The following is a description of a gene set: Genes containing one or more binding sites for (Ikzf3) in their promoter regions (TSS -1000,+100 bp) as identified by GTRD version 20.06 ChIP-seq harmonization. from publication Yevshin I, Sharipov R, Kolmykov S, Kondrakhin Y, Kolpakov F (PMID 30445619) Mouse Gene Set: IKZF3_TARGET_GENES studied in species Mus musculus, and this is the list of marker genes: Rps21, Fam221a, Mcoln3, Polg, Rps6ka1 (NCBI Gene Id 230803), Bivm, Neil1, Gm7285, Cert1, Mir3960, Mir1903, Chmp5, Bcl3 (B cell leukemia/lymphoma 3), Map4k2, Gpbp1, Socs2, Ap5b1, Elk3, Rimoc1, Ptges3, Serpinf1, Fus, Commd3, Casp7, A430093F15Rik, Tmbim6, Klf13, Cenpl, Cnot6, Lgals7, 1600023N17Rik (NCBI Gene Id 69788), Cblc, Pygo2, Spty2d1, Mir8120, 6030443J06Rik, Mapkapk5, Ttc28, Tcf19, Ptcd1, Itpripl2 (NCBI Gene Id 330636), Cdk20, Gcat, Nrm, Nup93, Tmbim4, Armc7 (armadillo repeat containing 7), Anapc16, Rnf216, Echdc3, Appbp2os, Klf9, Vamp4, Mib1, Man1a (mannosidase 1, alpha), Mir7653, Agfg1, Stk3, Hsd17b12, C2cd2, Gon7, 5730455P16Rik, Ints5, Txndc12, 2310030G06Rik, Fam98a, Tbkbp1, Itsn1, Pan3, Rpl13a, Arpp21, Lancl2, Mrps34, Mmachc, Grn, Heatr3, Vti1a, Cntrl, Wdr77, Tmem170b, Igkv13-82, Wrap53, Extl2, Pde6d, Cep41, Faap20, Gm15411, Megf8, 1700041G16Rik, Tlr4, Huwe1, A930006L05Rik, Cdh24, Bhlhe40, Btaf1, Stil, Fis1, Tet3, Erc1, Rrad, Timeless, Cdipt, Ppp1ca, Hsd17b4, B4galt5, Nfkbil1, Ubtf, Atp5mc3, Agpat4, Pcyt1a, Shprh, Gm23205, Ppp2cb, Ggnbp2, Dnajc1, Cilk1, Lrrc49, Mgarp, Scaf4, Spo11, Mef2d, Igsf8, Ndufs2, Akirin1, Dusp6, Mcm3, Adipor1, Mir1938, Alkbh5, Rag1, Rdm1, Rinl, Mir6361, Ston2, Klhl9, Ppp1r12b, Msh6, Mcl1, Ucp2, Ulk2, Gbp7, Zmynd8, Creb3l2, Lyrm2, Tmem87b, Apba1, Rnpep, Adam10, Vpreb1a, Tmx3, Rab35, Cimip2b, Mmut, Apc, Rsrc2, Nrdc, Rac1, Fnip2, 3110009E18Rik, Stat6, Frg2f1 (NCBI Gene Id 433752), Arfip1, a, Helz, Abhd18, Mmp14, Mex3c, Creb1, Spef2, A530072M11Rik, Mir7071, Eogt, Polr3b, Haus2, Tgif1, Neu3 (NCBI Gene Id 50877), Melk, Cep72, Chd9, Trappc9, Stx16, B3galnt2, Nudt16, Ankib1, Rab12, Pfkfb3, Gnb2, Cap2, Arih2, Adnp, Hexim1, Psma1, 9330136K24Rik, Cd3e, Calhm2, Arap1, Zbtb3, Polr3gl, Strip2, Pafah1b3, Gpt2, Dhrs7 (dehydrogenase/reductase 7), Bod1l, Gm17399, Atg14, Rps6ka2, Ankrd42, Arf2, Phip, Mcf2l, Ccdc88a, Kri1, Midn, Pold4, Gngt2, Carf, Mapk14, Cstf3, Calu, Dclre1a, Tradd, Lef1 (NCBI Gene Id 99641), A930002I21Rik, E230015B07Rik, Plxnd1, Arih1, Bag1, Usp46, Fam210a, Gm7008, 2810429I04Rik, Hipk2, Tmem222, Tti1, Kat6a, Irf2bp2, Prr29 (proline rich 29), Ndufb5, Rasgrp4, Cul7 (cullin 7), Tmem132a, Lnpep, Inpp1, Ankrd24, Nfyb, Slc25a30, Nbn, Rgl1, Gm10644 (predicted gene 10644, NCBI Gene Id 100126034), Nr1h3, Mettl21a, Etfb, Ptpn6, Suz12, Picalm, Rrp1, Ncoa2, Gm11613, Ten1, St7l, C87436, Tac4, Gm24000, Oard1, Chst10, Gm15417, Cst3, Phlda1, Dusp9, Cox14, Dbndd2, Traf1, Lpp, Tmem198b, Eva1b, Trpm8, Rab6a, Zfp91, Acp2, Ecsit, Rtn4, Gm17509, Hmbox1, Fam13a, F730043M19Rik, Rab4b, Arpc3, N4bp2, Gtf3c3, Zfp882 (zinc finger protein 882), H2-DMb2, Hnrnpll, Socs1 (suppressor of cytokine signaling 1), Vapa, Gne, Rgs3, Nrn1, Dzip3, Mir7655, Igsf10, Nfkb1, Gls2, Rcbtb2, Cuedc1, Pum3 (NCBI Gene Id 68885), Usp28, Gin1, Ttc39b, Dapp1, 1700001G11Rik, Ints9, Gm5540, Tbl3, Vps35l, Rhot1 (NCBI Gene Id 80692), Txn2, Thap7, 1810021B22Rik, Camta1, Commd4, Pih1d2, Msto1, Atp5pf, Grcc10, Fbxl4, Tyms, Usp32, Gabarapl2, Ubr1, Dmtf1, Srebf2, Mesd, Hsp90aa1, C78197, Gsto1, Snx21, Kat2b, Galnt2, Iqgap2, Mzf1, 9330159M07Rik, Htra2, Plpp3, Cipc, Zfyve1, Gm13982, Arid4a, Tnks (NCBI Gene Id 97475), Ippk, Hvcn1, Mlf2, C2cd3, Trp53i11, Dennd4c, Spmap2l, Nsd3, Efl1, 4631405J19Rik, Eya2, Acot8, 4833445I07Rik, Ampd2, Ctdsp2, Syde1, Eif2s1, Zfp326, Mttp, Inpp5d, Tfcp2, Gm57488, Plekhf1, Dock1, Uba2, Ppp2ca, Arid3b (AT-rich interaction domain 3B), Trbv31, Tsn, Tmem63a, Gsdmd, Gramd1a, St13, Foxp4, Cd47, Cecr2, Cenpu, Dgka, Mir3569, Ptprv, Arhgap31, Nrp1, Epb41l4b, Slc1a5, Nfkbia, Zfp281, 2010001A14Rik, Slc30a7, Uba7, Csrp2, Sestd1, Lonp2, Ttc39d, Pitpnm2, Prdx1, Mphosph9, Phykpl, 9230116N13Rik, Il17re, Malt1, Gphn, BC028471, Nfia, Ebf3, Mvb12a, Arpin, Mcrs1, Mrps25, Mtrfr, Ndfip2, Kctd18, Dvl3, Trerf1, Ccdc107, Syne3, Vrk3, Prkag1, Catspere2, Nhp2, Gm26802, Farsb, Gm5547, Sap30l, Csrp1, Rab1a, Dmap1, Adgrg1, Trim3, Pnn, Anapc7, Clpx, Adam17, Hbegf (NCBI Gene Id 225370), Mef2c, Mrpl21, Slc16a1, Rbbp8, Sh3rf1, Cntn2 (contactin 2), Tst, Gm12500, Tead4, Nhlrc2, Nhsl1, Ints3, Zscan12, Stn1, Pdzd2, Slc43a2, Zmynd12, Etv6, Spata6l (spermatogenesis associated 6 like), Ccar2, Mzt2, Pank2, Edaradd, Sfr1, Abtb1, Duoxa2, Map4, 1700003D09Rik, Gpr137, Hpcal1, Ramp1, Mir24-2, Mthfd1l, Mrps33, Pigw, Efcab14, Eif1ax, Dbi, Dusp5, Zfp609, Hnrnpul2, Fam110a, Pdk2, Wdr12, Igll1, A630014C17Rik, Rps19, Ncald, Ndufaf3 (NADH:ubiquinone oxidoreductase complex assembly factor 3), Trip4, Erc2, Kansl1, Setd7 (NCBI Gene Id 73251), Eps15 (epidermal growth factor receptor pathway substrate 15), Nabp1, Khdrbs1, Zbtb5, Antxr2, Myo19, Galnt10, Orc1, 0610038B21Rik, Prc1, N4bp2os, Pkn3, Cyfip1, Gpr19, Glrx2, Polr3d, Rbm25, Eml6, Acox1, Rab13, Cbfa2t3, Myo9b, Fam72a, E130102H24Rik, Mmgt1, 1700003G18Rik, Lpin2, Ppp1cb, Il16, Plekhg1, Cyb5a, Ssr3, Tecpr1, Zbtb44, Pik3cd, Crkl, Itm2c, Rfc1 (replication factor C (activator 1) 1), Gm16998, Dnajc13, Appbp2, Rexo4, Kyat3, Ubl5, Pals1, Klhl20, Fhod1, Mrpl32, Mir7666, 5031434O11Rik, Tfb1m, Fam3c, Ddx20, Ptbp3, Xrcc6, Gm33994, Slc39a8, 6720483E21Rik, Rab21, Myo18a, Ccdc163, Dynlt5, Notch2, D030040B21Rik, Slc15a3, Epo, Actr8, Hnrnpk, Dars2, Slc25a11, Mars2, Marveld1, Mir2861, 4930509H03Rik, Gm17484, Phactr4, Flrt1 (NCBI Gene Id 396184), Kmt2b, Gm11592, Cds2, Ppm1a, Clcn2, Ska3, F2r, Zfp318, Fchsd2, Gtf2f2, Ralgds, Tlr5, Osbpl1a, Sla, Fndc3a, Napg, Cd160, Csgalnact1, Cplx2, Kntc1, Gm6712, Btf3l4, Ppme1, Pxn, Gm26021, Zfp467 (zinc finger protein 467), Gtpbp2 (GTP binding protein 2), Ube3a, Sumo1, Heatr5b, Exoc3l, Akr1e1, Birc6, Idh1, Wdr36, Atp5mk, Luzp1, Cdk5, Sucla2, Serinc5, Dpy19l4, Vgll4, Foxp1, Ccdc88c, Caap1, Tmem176a, Lig1, Mir6936, Tha1, Tasor2, Ubash3a, Polg2, Vcl, Sbf2, Prkar1a, Sirt6, Tfpt, Zfp597, Jarid2, 2310010J17Rik, Rprd1b, Gm19569, 5830437K03Rik, Wscd1, Gm5558, Aamdc, Cnih4, Alkbh3, Abcg2, Asxl2, Sys1, Lat, Fbxo28, Mfsd10, Taf6l, Pisd, Gm10699, Lyrm1, Prkra, Mical1, Ganc, Calm1, Lbh, Dennd6b, Rcsd1, Tnk2, Ptms, Tbc1d32 (NCBI Gene Id 544696), Pik3r4, Cdc7, Cmc1, Pja2, Stmn1, Nfkb2, Zfp260, Tmc6, Flot2, Tob2 (NCBI Gene Id 73089), Prpf38a, Rps6ka3 (NCBI Gene Id 331563), Gpatch11, Gm15743, Cpd, Fbxo42, Ddx55, Nmnat1, Gm22890, Fstl4, Mlec, Pomgnt1, Tor1aip2, Stat1, Eif5, Capn3, Tnfrsf1a, Hdac7, Utp3, 4933406C10Rik, Rbfox2, Snap23, Zbtb7b, Mir27a, Pak1ip1, Bmyc, Rmrp, Cpsf4l, Gm30238 (NCBI Gene Id 102632066), Pik3r1, Tfg, Dusp11, Maz, Prmt5, Bloc1s1, Cln8, Nab2, Spred1, Dis3l, 5730471H19Rik, Hemk1, Gm26611, Gm42759, Lrrc1, 4933439C10Rik, Gm12059, 1700025G04Rik, Zbtb14, Endov, Hnrnpl, Mettl9, Fhip1b, Fbxl12, Cdk9, Dclre1c, Fam78a, Cep19, Igsf9, Gpaa1, Ttbk2, Nutf2, Agk, C1qtnf12, Parvg, Ctsd, Senp2, Adcy7, Sde2, Mrpl48, Noct, Cep70, Dctn1, Rbpj, Mcu, Atosa, Dpagt1, Fam3a, Gm13620, Ngdn, Tmtc3, Acaa2, Mis18bp1, Tbc1d10c, Ppcs, F13a1 (coagulation factor XIII, A1 subunit), Polk, Pex19, Rasgrp3, Smarcd2, Camsap2, Nop16, 2310044K18Rik, Khsrp, Slc9a8, Atg16l1, Rad54l, Zfp788, Tmco4, Cfap45 (cilia and flagella associated protein 45), Slc35a1, Adi1, Tmcc1, Psmd2, Ddx59, Akr1b1, Fut8, Ammecr1l, Ube2e1, Gm36981 (NCBI Gene Id 105244476), Bace1, Xiap, Jkamp, Zap70, Vsir, Taok2, Gpr180, Styk1, Esyt2, Matn2, Ctnnb1, 2810408I11Rik, Rreb1, Fxr2, Smap1, Utp25, Nsfl1c, Nfat5, Gm13421, Rhoh, Oas1c, Rab14, Wbp1l, Ift122, Asph, Fkbp1a, Mgat5, Nf1, Spats1, Tmem204, Tcf12, Raly, Sema3f, Tgif2, Gm26839, Slc44a1, Cdr1, AI480526, Tmx1, Zdhhc20, Saxo2 (stabilizer of axonemal microtubules 2), Mcur1, Rab10, Rnf185, Becn1 (beclin 1, autophagy related), Rb1, Arhgef12, Galk2, Vps26c, B230217C12Rik, Sec22a (NCBI Gene Id 69021), Oas1b, Nadk, Acp5, Mtif2, Mei4, Syk, Ogg1, Phospho1, 1110002L01Rik, Otud1, Fbxo21, Eif4a3, Gm5493, Gtpbp6, Bad, Zfp948, Tcf4, Palb2, Arhgap21 (NCBI Gene Id 98793), Rapgef3, Myo6, Tinf2 (Terf1 (TRF1)-interacting nuclear factor 2), Pik3ap1, Alms1, Pik3ca, 1700055D18Rik, Cfap276, Aaas, Kcne3, Fgd2, Atxn7l1, Scd2, Fubp3, Dctn5, Gas7, Zfp64, Optc, Bbs4, Prkci, Gm15564, Slc25a14, Hk1os, Efcab2, Mcoln1, Foxj3, Jakmip1, Blmh, Tmem18, Ttc4, Itgb2, Serhl, Ttll11, Dnai3, Htt, St3gal3, Amotl1, Rhebl1, Duox2, Ntpcr, 6430573P05Rik, Tnfaip8l1, Srf, Xrra1, Rai1, Gm16578, Copa, Nkapd1, Hivep2, Fads2, Gosr2, Cers6, Hat1, Ankrd12, Ikbkg, Trim25, Cnn3, Mepce, Tsku, Fhl4, Hmg20b, Smarce1, Mitd1, Ptp4a3 (protein tyrosine phosphatase 4a3), Plscr1, Mfng, Atxn2l, Mospd1, Elp6, Pkn1, Hdac5, Rbm43, Cep162, Map3k1, C130021I20Rik, 2610005L07Rik, Fh1, Nr1d1, Hjurp, Zdhhc6, Gas2l3, Nabp2, Gigyf2, Gm9958, Foxc1, Hinfp, Ccdc120, Hs2st1, Cep290, Tmem109, Chst3, Cnksr3, Cacnb2, Rassf5, Mir3091, Med1, Alcam, Eme2, Yap1, Slco3a1 (solute carrier organic anion transporter family, member 3a1), Rpl31, Clock, Pidd1, Gm37120, Tbc1d8b, Naa30, Tmem65, 2810402E24Rik, Shld1, Sp1 (NCBI Gene Id 68485), Wdcp, Echdc2, Dtwd1, BC043934, Spn, Lypla2, 1810008B01Rik, Gm12301, Lasp1, Lhfpl6, Matcap2, Gsk3b, 1110006O24Rik, Atn1, Smarcal1, Ddx50, Slc43a1, 1700120B22Rik, Dgkg, Cnot3, Ctnna1, 6820408C15Rik, Ric8b, Brpf1, Arl6ip5, Gabpb1, Polr2i, Rcor3, Bdh1, Bcl2l1, Zfp960, Dnlz, Kctd11, Gm266, Spin4, Slc25a38, Cchcr1, Jmy, Plxdc2, Ghr, Mir320, Exoc5, Eif4a2, Msrb2, Gstm1 (NCBI Gene Id 14862), Gm14455, Gm2093, Snx33, Acad9, Psrc1, 1700086O06Rik, Pdcd6, Ly6m, Laptm4b, Mtg2, Id3, Odr4, Mmgt2, Gm13920, Ubxn2b, Fry, 1810009A15Rik (RIKEN cDNA 1810009A15 gene), Ptpn3, Srfbp1 (serum response factor binding protein 1), Calm3, Pes1, Sh2b3, 4930589L23Rik, Ajuba (NCBI Gene Id 16475), Itgb1, Wdfy4, 1700125G22Rik, Casp2, Homer3, Bsn, Pjvk, Ophn1, Fam133b, Plpp5, Rab34, Sirt7, Degs1, 2310068J16Rik, Stoml1, Zfp473, L3hypdh, Chd8, Tbc1d23 (TBC1 domain family, member 23), Fastkd3, Klf11, Spata6, Kmt2a, Kpnb1, Pde10a, Chid1, Exoc2, 1810037I17Rik, Vangl2 (VANGL planar cell polarity 2), Lyl1, Rictor, Ubl3, Slc39a1, Gm11690, Avpi1, Nvl, Acss2, Aff1, Fn3k (NCBI Gene Id 80558), Dek, Naf1, Znhit1 (NCBI Gene Id 70103), Rnf167, T2, Hsd17b11, Eif6, Ube2e2, Ago3, Rnf20, Kansl3, Gm16894, Polr1d, Pcna, Foxo4, Dync2h1, Kctd14, Ccnd3, Mtfr1l, Trem1, Clip1, Rab5a, Gtdc1, Polm, Tsc22d1, Cacna2d2, Mtch1, Mamstr, Ift27, Rab33b, Cyria, Thap12, Gusb, Smc5, Kmt2d, Ifrd1, Slc35b2, Shb, Arhgef10, Stam2, Cep57, 9930012K11Rik, Dleu2, Selplg (NCBI Gene Id 20345), Thtpa, Rdh5, Inppl1, Pla2g6, Psmd5, Gm15927, Pramel12, Syngr1, Dnajb12, BC034090, Pakap, Phf23, Ranbp9, Notch1, Nup54, Dpysl2, Srsf7, Lmx1b, Leng9, Kifap3, Mir191, Gnai2, Snx27, Rnps1, Ost4, Rbm34, Hfe, Aplf, Pdcl3, Eif2d, Gmds, Gpatch8, Ric8a, Gm4221, Wdr3, Jcad, Ciao2b, Pip4p2, Gm17249, Zc3h12c, Cap1, Pomk, Abi3, Itgav, Fam76b, Nynrin, Esyt1, Kirrel1, Rac2, Zfp420, Pou2f1, Ssc4d, Ubr7 (ubiquitin protein ligase E3 component n-recognin 7 (putative)), A730081D07Rik, C230035I16Rik, Btbd2, Rasgrp2, Dynlrb1, Pigc, Slc45a4, Erbin, Prps2, Zfp395, Tmem87a (NCBI Gene Id 211499), Pura, Kpna4, D330041H03Rik, Lrp6, Mllt3, A730035I17Rik, Zscan22, Stag1, Chaf1a, Phf21a, Dicer1, AV099323, Brca2, Fam13b, Bmp2k, Acvr1, Haus8, Ap2a1, Zfat, Zfp286, Frmd6, Zswim3, Hook2, Cttnbp2nl, Nfam1, Elapor1, Fbxo10, Cep250, Uaca, Apbb2, Zfp36l1, Tmem229b, Nus1, Jun, Rbm45, Efemp2, Zmiz1, D930048N14Rik, Cyp2j6, Rdx, Col25a1, Ncdn, Coro1b, Prkca, Trib1, Gm11454, Ctc1, Cdan1, Gdi1, Ppp1r8 (NCBI Gene Id 230788), Abi2, Gtf2f1, Zfp267, Asb6, Filip1, Vcf1, Pigx, Iftap, Gm15327, Stam, Deptor, Fam76a (family with sequence similarity 76, member A), Gm5447, Slc4a2, Atp2c1, Mgat1, Itpk1, Rnf44, Xpnpep3 (NCBI Gene Id 321003), Eeig2, Gpx1, Il7r, Dna2, Pus10, Tvp23a, Nbdy, Dcun1d5, Capg, Scd1, Trabd2b, Slc66a3, Tlnrd1, Trip12, Emsy, Wbp4, Bmf (BCL2 modifying factor), Tmtc4, Fbxo11, Slc49a4, Tbrg4, Zbtb38, Ripk2, Gm23119, Pgls, Gm12107, Zcwpw1, Mrpl52, Med13, 4930578M01Rik, Scarna17, Stx12, Cdiptos, Cln6, Mknk2, Drosha, Cers5, Cltc, Gfra2 (NCBI Gene Id 14586), Psma2 (proteasome subunit alpha 2), Rps26, 5930430L01Rik, Trpm1, BC002059, Gm9530, Capza1 (capping actin protein of muscle Z-line subunit alpha 1), Pter, Junb, Ctdnep1, Mtmr6, Smad3, Setd1a, Tspan5, Sphk1, Stap2, Fcgr1, Dnhd1, Gtf2i, Ramacl, 8430429K09Rik, G3bp1, Top3b, Xpo5, Plekhf2, Sla2, Smim13, Cux1, Rpl36, Zfp622, Wdr11, Sypl1, Sdf2l1 (stromal cell-derived factor 2-like 1), Gng2, Ankhd1, Tanc1, Ctif, Sh2d3c, Mis12, Manba, Cfap96, Zfp944, Nmi, Taf5l, Zfp668, Cd93, Arl16, Tpr, Selenof, Spr, Npdc1, Nubp1, Gpr108, Mir7688, Mir8099-1, Frmd4a, Plekho2, Rnf31, Kazald1, Cnnm4, Rbm4b, Ttc17, Sardh, 6430548M08Rik, Mfap1a, Nwd1, Lnx2 (ligand of numb-protein X 2), Atad2, Adcy3, Zcchc7, Ppp1cc, Echdc1, Zfp408, 6030458C11Rik, Plekha6, Chrac1, AV039307, Nr2c2 (nuclear receptor subfamily 2, group C, member 2), Golph3l, Pcbp2, H1f2, Cacnb3, Vrk1, Gm25541, Osgepl1, Kat6b, 2310057M21Rik, 4930426L09Rik, Arf1, 1700036A12Rik, Mtnap1 (NCBI Gene Id 28086), Rptor, Hmgb2, Med14, Slx1b, Rhog, Lrig2, Csnk1g1, Cep170, Slc25a1, Plekha7, Arhgap1, Baz1a, Rpl29, Bbs7, Snw1, Pdcd11, Dcun1d3, Fbxl19, Hsd17b10 (hydroxysteroid (17-beta) dehydrogenase 10), Cand1, Ict1os, Podnl1, Efhc1, Pa2g4, Tial1, Plekhg3, Rab4a, Kcnb1, Lcorl, Car2, Smim30, Cimap1b, Ist1, Wiz, Tars2 (threonyl-tRNA synthetase 2, mitochondrial (putative)), Fbh1, Smg9, Ibtk, Zfp185, Zfp13, Srl, Klc3, Akna, Lzic, Usp40, Elk4, Pi4k2b, Tnks1bp1, Zfp945, Zfp111, Litaf, Nr6a1, Zfp687, Cryzl1, Ppp1r15a, Map3k12, Lrrc57 (leucine rich repeat containing 57), Vdac1, 4930558K02Rik, Cpsf4, Abhd1, Tram1, Mrpl24, Nup155, Arhgap11a, Clta, Homer1, Acaa1a, Ankrd16, Eloc, Mllt6, Fem1c, 1700028E10Rik, Lsp1, Arc, Orc5, Gm14634, Spred2, Plod3, E2f3, Cotl1, Tbrg1, Trio, Lxn, Rpl37, Mbtps1, Naa60, Rsu1, Ubap1, Pianp, Gm29707, Stambp, Myb, Gm27003, Bcl11a, Elp3, Serpinb9, 6820431F20Rik, Gdap2, Plin3, Plekhg2, Washc3, Arid3a, Stk26, Snord60, Tnk2os, Senp1, Zfp384, Far1, Fhit, Kifc5b, Lrrc75a, Skp2, Plekha4, Trgv2, Pgghg, Arid1a, Gm13783, Asf1b, Dnajb14, Zfp704, Rwdd1, Acss1, Ireb2, P4hb, Dus4l, Lmna, Uspl1, Sgk1, C1ra (complement component 1, r subcomponent A), Sec24d, Serpini1, Champ1, Tifa, Galt, Slc39a11, Slc39a13, Cldn12, Lbhd1, Sirt4, Lamb2, Mindy4, Pstpip1, Urb2, Cip2a, Cops7b, Ap5m1, 3110056K07Rik, Anxa11, Pon3, Mphosph8, Gm26876, Pwwp3a, Cmtm7, Ntaq1, Ehhadh, Trim41 (NCBI Gene Id 97771), Tbc1d4, Ncapg, Zfp213, Gm12915, A230083N12Rik, Zfand2a, Mir5135, Zfp637, Junos, Srgn, Psme2, Slc2a9, Mir142hg, Gm26511, Eny2, Gm37548, Synpo, Prpf31, Ttc9c, Pip4k2a, Wwc2, Psmb3, Zfyve26, Arhgef1, Kmt5c, Entpd7, 1110019D14Rik, Ctcf, Actn1, Tmem106c, Cyren, Usp3, Zfp282, Insl6, Micall2, Emilin1, Tmem250, Hspbap1, 4930532G15Rik, Commd8, Arhgap45, Traip, Agap1, Aup1, Tcf25, Lmbrd2, Alg1, Matr3, Cdt1, Agl, Pdcd10, Desi1, Rmdn1 (NCBI Gene Id 78089), Pde4a, Atp6v1d, Ufsp2, Pdp2, Snord118, Polh, Ciz1, Tnfaip3, Sh3kbp1, Trabd, Ikzf4, Mpst, B230319C09Rik, Srgap2, 1700082M22Rik, Dennd2c, Tcf7, 5730420D15Rik, Bcor, Tubgcp5, Maml3, Gm15612, Atp10d, Mbd4, Chaf1b, Atg3, Gm10687, Pten, Pde4c (phosphodiesterase 4C, cAMP specific), Gm13562, Gm13033, Gramd2b, Tmem176b, Nav2, Ifit2, 6430590A07Rik, Fbxo36, Erbb3, Ldlr, Mm2pr, Anapc1, A630072M18Rik, Trmt10a, Vwf, Ogfr, Arhgef39, Eif3k, Ppp3r1, Nfya, Rasa1, Gm13022, Elp5, Hibadh, Uqcrb, Drg2, Bola2, Zer1, Gm13814, Safb, Safb2, Rprd1a, Zdhhc17, Gm26513, Zfp523, Cep350, Cdk13, Sit1, Polr2a, Tbpl1, Ighmbp2, Casp8, Derl2, Gins2, Krit1 (KRIT1, ankyrin repeat containing), Glipr2, Zfp236, Tbc1d8, Gm17473, Gm12522, Zfp646, 4930580E04Rik, Magohb, Gbp3, Rab26os, Gm10524, Kazn, Fam227b, Virma (NCBI Gene Id 66185), Ccm2, Wdfy3, Map4k1, Mad2l1, Ext2, B230217O12Rik (NCBI Gene Id 320879), Mboat1 (membrane bound O-acyltransferase domain containing 1), Spcs2, Ate1, Zfp7, 4932412D23Rik, Camk1d, Nfkbid, Axin2, Sec11c, Mtrr, Gm11205, Srrm1, Cdc42se2, Ldb1, Rnmt (NCBI Gene Id 67897), Arhgef4, Rab18 (RAB18, member RAS oncogene family), Ddhd2, AU040320, Setd1b, Pradc1, Fbxw4, Gm5464, Mgat4b, Sigmar1, Sh3bgrl3, Odad1, Hgs, Nfxl1 (nuclear transcription factor, X-box binding-like 1), Ppp1r18, Pxylp1, Ascc1, Aldh7a1, Dnph1, Jade2, Lrba, Arhgap35, Cdkn2aipnl, Slc9a5, Trmt11, Atp5pb, Gm14167, Ubxn11, Rab9, Slc35a5, Upp2, Map3k5, Cdk19, Dcaf12, Reps1, Rusc1, Naa16, Septin9, Eng, 4933405D12Rik, Ahctf1, Ankrd6, Brd3, Rsf1, Zzz3, St6gal1, Mbd5, Dusp2, Mrpl30, Cr1l, Uqcc3, Cabp1, Il12a, Eprs1, Firre, Gprc5c, Ap1s1, Usp9x, Rtf2, Lrrn3, Gm8093, Aunip, 4930515G01Rik, Spryd7, Tmc8, Zmiz1os1, Wrnip1, Stard3, Stradb, Tsc22d4, Endou, Fas, Wdr37 (WD repeat domain 37), Vps26a, Bnip3l, Pex13 (NCBI Gene Id 72129), Zfp608, Gm13270, Ncstn, Alg13, Leprot, Dhrs13, 4930449I04Rik, Llgl2, Erich1, Dnaaf11, Pkp4, Gosr1, Smg7, Ppp2r1a, Zc3h15, Orc4, Rassf1, Sec63, Traf7, Mir23a, Cish, Ulbp1, Pgpep1l, Ubald1, Ripor1, Papss1, Gm15408, Bzw1 (basic leucine zipper and W2 domains 1), Pdf, Plpp6, Slfn10-ps, 2700097O09Rik, Strn3 (striatin, calmodulin binding protein 3), Trim35, Rmi1 (RecQ mediated genome instability 1), 1110018N20Rik, Eef1a1, Mprip, Cdk5rap2, Btg1, Wdr81, Napepld, Tlcd1, Rhobtb2, Zfp574, Map3k7, Ankrd17, Nipbl, Spsb4, Tns2, Prrg1, Ptges2, Gm10614, Ywhab, Arhgap10, Zfp605, B3galt5, Arl6ip1, Snora57 (NCBI Gene Id 118027464), Cyp4f16, Slc16a6, Upf1, Mrtfb, Snapc3, Cd81, Ubr5 (NCBI Gene Id 97951), Obsl1, Ctnnd1, Gm27008, Mir5136, Adora2b, Mospd3, Slc37a3, Kdm4c, Itpr1, Il1r2 (NCBI Gene Id 16178), Samd4, Nudt13, Usp18, Nf2, Dap3, Zfp112, Erbb2, Usp6nl, Pros1, Mapk1ip1l, Mbd6, Chd2, Upf2